The following is a description of a gene set: Human Gene Set: WP_JAKSTAT_SIGNALING_AND_ARTD_FAMILY_MEMBERS studied in species Homo sapiens JAK/STAT signaling and ARTD family members, and this is the list of marker genes: SKP1, PARP1, STAT6 (NCBI Gene Id 6778), CUL1, BTRC, PARP11, HDAC3, STAT3, PARP9, RBX1, DTX3L, STAT1, HDAC2, PARP14